The following is a description of a gene set: Genes down-regulated in comparison of B cells versus effector memory CD4 T cells. In the present study we used Affymetrix oligonucleotide microarrays to produce gene transcription profiles for the major leukocyte types in humans. This comprehensive dataset enabled us to not only establish which genes were expressed in each leukocyte type, but also which genes were expressed in each subset after activation. The used of a comprehensive dataset of gene profiles from all the major human leukocyte subsets enabled a novel and powerful means for identification of genes associated with single leukocyte subsets, or different immune paradigms. from publication Jeffrey KL, Brummer T, Rolph MS, Liu SM, Callejas NA, Grumont RJ, Gillieron C, Mackay F, Grey S, Camps M, Rommel C, Gerondakis SD, Mackay CR (PMID 16474395) Human Gene Set: GSE3982_BCELL_VS_EFF_MEMORY_CD4_TCELL_DN studied in species Homo sapiens, and this is the list of marker genes: LRRFIP1, MVB12B, WDR76, PENK (NCBI Gene Id 5179), CST7, KLRF1, IL7R, ENOSF1, BEAN1 (brain expressed associated with NEDD4 1), RAB11FIP5, CCDC9, CNIH3, CX3CR1, PHOX2A, RIBC2, FBXO22, PTP4A3, CHRNA9, SLC2A3, KRT75, EXOC6B, ALOX15B, PXN, LGI2, PTGDS, MRC2, FGF18, STIL, NHLH2 (NCBI Gene Id 90888), DSTN, ANKS1B, ZNF674, AK1, ZNF12, CLCA4, OASL, TAS2R14, GRAP2, COL5A3, LDLRAD4, DLX4, B2M, SATB1, AOAH, PLXND1, HOXB6 (NCBI Gene Id 3216), ESR2, OTUD7B, SLC34A1, PYHIN1, ATP4A, RORB, ADCY10 (NCBI Gene Id 82259), HABP4, CHI3L1, MAGEA10, APOBEC1, CREB3L1, ZNF365, RAD51, ERC1, DCBLD2 (NCBI Gene Id 131566), LRP12 (LDL receptor related protein 12), MYF6, SHTN1, PLEC, ITGAL, EDN3, EXTL2, FABP7, H4C4, ZFR2, ANXA1, OR3A1, ZCCHC24, NDRG1, A4GNT, ABCC5, MYLK3, ARHGEF26, MUC1, DMWD, CETP, MAB21L2, RASGRF1, MYO10, NLGN1, NCKAP1, ANTXR1, ARL4C, LPIN2 (NCBI Gene Id 9663), CORO2A, CCL22, ETV6, LONRF3, CACNB2, H3C12, ZNF91, SPINK1, ETV3, CSTPP1, CD248, TRPV4, APOBR, SOX13 (NCBI Gene Id 9580), SAMHD1, TARP, NMU (NCBI Gene Id 10874), ZNF197, EPHA5, GZMM, HOXD11, FKRP, SH3GL2, ARRB1, COPZ2, HES2 (NCBI Gene Id 54626), PAM, SH2D4A, KRT34, KRTAP1-3, EPPIN, PDE10A, GUCY1B2, HTRA1, CIT, CDHR5, HCRTR2, TMC5, CLIC5, HTN3, BAG3, TXLNGY, P2RY13, COL10A1, DOK2, LIFR, BMP1, SALL1, CD300A, LAMA4, MAOB, NPTXR, ALDH1A2, OR7E87P, KIR2DS2, TRPC7, NCAPG2, SEMA4C, ALDH3B2, OR2B2 (NCBI Gene Id 81697), RIPPLY3, SHH, CMKLR1, SH2D3A, FRAS1, ANO1, CASP6, HELZ, SLC28A3, RRM1, SMR3A, MYCN, PDE3A, GSTT2, STRADA, TNFRSF1A, LOX, RUSC1, TNNC1, TRIAP1, BBS9, DHDDS, CCNT1, CYP4F11, PLIN1, PRR14L, KLK14, CLEC4M, CATSPERZ, ZNF480, ANGPT1, AMMECR1, RBP4, GGA1, MEIS1, B3GALT1, LDHB, NXN, TRIM45, STAB1, PSMD1, FECH, SLC12A3, SLC30A3, FCF1